The following is a description of a gene set: Human Gene Set: GSE360_LOW_DOSE_B_MALAYI_VS_M_TUBERCULOSIS_DC_UP Genes up-regulated in comparison of dendritic cells (DC) exposed to 5 worms/well B. malayi versus DC exposed to M. tuberculosis Monocyte-derived dendritic cells (DC) and macrophages (MΦ) generated in vitro from the same individual blood donors were exposed to five different pathogens, and gene expression profiles were assessed by microarray analysis. Responses to Mycobacterium tuberculosis and to phylogenetically distinct protozoan (Leishmania major, L. donovani, Toxoplasma gondii) and helminth (Brugia malayi) parasites were examined, each of which produces chronic infections in humans yet vary considerably in the nature of the immune responses they trigger. species: Homo sapiens from publication Chaussabel D, Semnani RT, McDowell MA, Sacks D, Sher A, Nutman TB (PMID 12663451), and this is the list of marker genes: UBAC1, RPS3A, CTCF, CLIP2, ADH6, CR1, CYP26A1, TEX261, NISCH, CYLD, HMGA1, ADORA3, ITM2B, SMIM10L1, NDUFA7, CAPN11, RBL2, SORL1, PEPD, CAPZB, ZNF81, PECAM1, CAMTA2, ACAA2, SYK, ICAM3, EIF3F (eukaryotic translation initiation factor 3 subunit F), LPXN, MEGF9, GRAMD4, FIG4, FCER2, SULT1C2, FOXO3, TNFRSF10B (TNF receptor superfamily member 10b), MCM3AP, GGA2, RNMT, MARS1, H2AZ1, H2AZ2, TPM1, RNH1 (ribonuclease/angiogenin inhibitor 1), RPL5, PHB2 (prohibitin 2), ALOX5, RNASE6, RANBP3, TRAPPC3, PLXNB2, APOC1, FBL, RPL7, SPTAN1, SIVA1, F13A1, IDH3A, PIP4K2B, RNF167, RPS27, PPM1A, SASH3, CD52, ERF, TXNIP, OR2F1, LAMB2, PCSK5, DGAT1, CAT, TARS1, RGS10, HEBP2, KDELR1, TP53, PLCB2, PNPLA6, MAN2A2, ADAM15, STAB1, SUGP2, GAS7, TSPYL4, ADAM12, EIF4B, ZFP36L2, IER2, ITGB5, PARP1, MAGED2, MACROH2A1, CNOT3, ATP4A, GFRA2, PEMT, SIPA1L3, MRC1, RERE, LTA4H, UQCRC1, NCF4, FAM131A, SGK1 (NCBI Gene Id 6446), ST18, XBP1 (NCBI Gene Id 7494), PTP4A2, CUL7, RECQL5, PQBP1, RASSF1, LMO2, HBE1, JUND, PSEN2, RAB32, RPL34, GNB1, SPAG7, PRDX2, CDC5L, TMEM109, SMAD5, SLC7A5, SLC1A5, HMGCS2, MSMB, RRP1B, PFKFB1, ALDH2, BAAT, ASIC1, ADCY7, RAB33A, DAP, CLTB, GGA3 (golgi associated, gamma adaptin ear containing, ARF binding protein 3), NCOR2, DUSP7, SMARCE1, RNASE1, GLB1 (NCBI Gene Id 2720, galactosidase beta 1), S100A4, ZC3H15, RPL21 (ribosomal protein L21), S1PR2, CSRP1, LYL1, ITGAM, DR1, DUT, CDC25A, TBL1X, CPVL, SH3BGR, GTF2A2, AHCY, RBM4B, TKT, LY86, SNU13, CHN2, FOLH1, NACA, SGSM2, CCNH, NDUFS4, ASTN1, INPP1, KATNA1, ASAH1, TBC1D1 (TBC1 domain family member 1), SLA, P2RY11, MPV17, CNPPD1, EEF1G (NCBI Gene Id 1937), COX4I1, RGS19, ADD1, ABCC5, TMEM158, WDR43, SRCAP (NCBI Gene Id 10847), FCGRT, ERP29, MLEC (malectin), USP4, CAMK1, ANP32A, TAGLN, SPARC, SSRP1, MDM2, STK38, CUL4A, PTOV1 (NCBI Gene Id 53635), ADD3, SEC31A, HDAC3, SELENOP